The following is a description of a gene set: In addition to various processes for removing lesions from the DNA, cells have developed specific mechanisms for tolerating unrepaired damage during the replication of the genome. These mechanisms are collectively called DNA damage bypass pathways. The Y family of DNA polymerases plays a key role in DNA damage bypass. <p>Y family DNA polymerases, REV1, POLH (DNA polymerase eta), POLK (DNA polymerase kappa) and POLI (DNA polymerase iota), as well as the DNA polymerase zeta (POLZ) complex composed of REV3L and MAD2L2, are able to carry out translesion DNA synthesis (TLS) or replicative bypass of damaged bases opposite to template lesions that arrest high fidelity, highly processive replicative DNA polymerase complexes delta (POLD) and epsilon (POLE). REV1, POLH, POLK, POLI and POLZ lack 3'->5' exonuclease activity and exhibit low fidelity and weak processivity. The best established TLS mechanisms are annotated here. TLS details that require substantial experimental clarification have been omitted. For recent and past reviews of this topic, please refer to Lehmann 2000, Friedberg et al. 2001, Zhu and Zhang 2003, Takata and Wood 2009, Ulrich 2011, Saugar et al. 2014. part of: DNA Repair species: Homo sapiens Reactome Pathway: DNA Damage Bypass, and this is the list of marker genes: RFC1, CUL4A, VCP, REV3L, MAD2L2, UBA52, ISG15, USP1, CUL4B, POLI, RPA1, POLE3, RPA3, USP10, POLE2, RFC4, RFC5, RFC2, POLH, WDR48, UBA7, PCLAF, POLD1, REV1, RPS27A, POLD3 (DNA polymerase delta 3, accessory subunit), RCHY1, UBC, POLK, RPA2, DDB1, DTL, UBE2L6, UFD1, RBX1, PCNA, UBE2B, POLE, RAD18, POLD2, POLE4, NPLOC4 (NPL4 homolog, ubiquitin recognition factor), POLD4, USP43, TRIM25, RFC3, SPRTN (SprT-like N-terminal domain), UBB (NCBI Gene Id 91253)